The following is a description of a gene set: species: Homo sapiens Human Gene Set: HP_ABNORMAL_CSF_SERINE_FAMILY_AMINO_ACID_CONCENTRATION Any deviation from the normal concentration of serine-family amino acids in the cerebrospinal fluid. Abnormal CSF serine family amino acid concentration, and this is the list of marker genes: GCSH, IBA57, BOLA3, NFU1, GLYCTK, AMT, GLRX5, PSAT1